Given this list of marker genes PLXNC1, SMAP1, ZBP1, AMMECR1, ALCAM, CHST11, PSMD8, CRYBG3, JPT1, S100A4, HERPUD1, TTC39C, IQGAP2, TMEM64, CBLL1, PIEZO1, GZMK, SUSD6, MLF1, ZBTB38, ADAM19, PMAIP1, PLP2, ATP2B1, REEP3, LGALS1, EEPD1, CD82, MAP3K5, CD58, MAGOH-DT (MAGOH divergent transcript), PHTF2, YWHAH, CASK, TOR3A, CD74, DUSP10, ST8SIA1 (ST8 alpha-N-acetyl-neuraminide alpha-2,8-sialyltransferase 1), ATXN1, SH3BGRL3, COTL1, RAB11FIP1, ATP2B4, RORA, TNIP1, GSTK1, MAF, PRC1, TIGIT, ARPC1B, LGALS3, SNX24, GPRIN3, DUSP5, GNAI2, ZC2HC1A, PRDX1, MIB1, TBK1, GATA3, NCOA7, VDAC1, MIS18BP1, SLC9A9, EHD4, ACVR1, MYL6, SMAD3, SRGN, SSR3, MYBL1, SNX10, REEP5, RILPL2, ARL6IP1, MIAT, IL2RB, TTYH2, ACOT9, CTSA, NABP2, CAPN2, TIFA, WEE1 (WEE1 G2 checkpoint kinase), PREX1, RSU1, SEC11C, SMC6, MCOLN2, EVI2B, CORO1B, GLB1, LIMS1, PRKCD, GPR183, PDP1, CXCR3, FBXL8, RNF214, ELAPOR1, TRADD, ACTB, TANK, TAGLN2 (NCBI Gene Id 8407), OSBPL3, LPP, RFTN1, ENDOD1, NIBAN1, CDCA7, PEA15, HNRNPLL, IQGAP1, LDHA, KLRB1, CLIC1 (NCBI Gene Id 257617), DENND10, TGFBR3, ETV6, SPPL2A, STOM, PHACTR2, S100A11, TIMP1, EPHA4, RNF135, PTTG1, EZR, TUBB4B, HLA-DRB1, SLC6A6, RNF139 (ring finger protein 139), MYO5A, RAB27A, SLC35D2, GOLGB1, OPTN, RNF19B, SQOR, ARHGAP18, OGDH, LRIG1, LIMS3, RAP1GAP2, DIAPH2, ITGB1, PYHIN1, ARHGAP35, GSE1, TNFRSF4, HMGB2 (high mobility group box 2), FAR2, CRIP1, NHERF1, AHNAK, AUTS2, FAS, KIF1B, MYO1F, NABP1, GOLGA7, IFI16, TP53INP1, NBEAL2, SLC2A3, TOM1, DHRS7, CDC42EP3, DEGS1, KLF6, EPS15, NOD2, TNFRSF1B, SYNE2, SH2D1A, CLDND1, ELOVL5, AQP3, TBCB (tubulin folding cofactor B), SIAH2, ANXA2, AKIRIN2, CD99, PFKP, TPM4, PDIA6, GLIPR1 (GLI pathogenesis related 1), UBL3, ANXA4, IL10RA, ANXA1, SEL1L3, AHR, CD84, EMB, CCR6, CHST7, RAPGEF1, here is a description of the gene set: from publication Abbas AR, Wolslegel K, Seshasayee D, Modrusan Z, Clark HF (PMID 19568420) Human Gene Set: GSE11057_NAIVE_VS_MEMORY_CD4_TCELL_DN studied in species Homo sapiens Microarray deconvolution is a technique for quantifying the relative abundance of constituent cells in a mixture based on that mixture's microarray signature and the signatures of the purified constituents. It has been applied to yeast and other systems but not to blood samples. Here we test the ability of this technique to determine the fractions of subsets of memory T cells in peripheral blood mononuclear cell (PBMC) samples. Genes down-regulated in comparison of naive T cells versus memory T cells.